Given this list of marker genes Hdac4, Tgfb1, Ccnd1, Ep300, Cbfb, here is a description of the gene set: This event has been computationally inferred from an event that has been demonstrated in another species.<p>The inference is based on the homology mapping from PANTHER. Briefly, reactions for which all involved PhysicalEntities (in input, output and catalyst) have a mapped orthologue/paralogue (for complexes at least 75% of components must have a mapping) are inferred to the other species. species: Mus musculus part of: Transcriptional regulation by RUNX3 electronically inferred by orthology from the curated human pathway Reactome Pathway: RUNX3 regulates p14-ARF